Given this list of marker genes Yipf6, Trmt61b, Gm7369, Opn1sw, Prss41, Nherf2 (NCBI Gene Id 76520), Aim2, Gm25894, Gatad1, Amt, 9130213A22Rik, Slc35a4, Gphn, Yif1a, 2300009A05Rik, 1110018N20Rik, Akap7, Dok1, B230369F24Rik, Gm13624, Gm9873, Ldha, Fthl17f, Rps29-ps, Mir1894, Ech1, Gpr143 (G protein-coupled receptor 143), 2010109A12Rik, Hoxd3, Tanc1, Cyb5r4 (NCBI Gene Id 97535), Smarce1, Sec61a1, Ralgds, Phf21b, Sun2 (Sad1 and UNC84 domain containing 2), Sertad1, Mcm3ap, Tpd52l2 (NCBI Gene Id 99179), Nup155, Ccdc88c, Npas1, Dnah1, Zfp799, Tbl3, Slc3a2, Gm8098, Folr1, Tubgcp6, Mapk8ip2, Catsperg1, Gm12803, Calb1, Herpud1, Snap47, Sptbn1, R3hcc1l, Bbln, Nampt, D030040B21Rik, Ranbp17, Ctbp1, Tmtc1, Rnf167, Mtmr4, Nrtn, Izumo4, Ccdc191, Ubxn2b, Mid2, Exosc7, Patl1, Tedc1, Hpse, Trp53i11, Rbpms, Cpeb3, Ncor2, Mmaa, Gtf3c6, 4930568A12Rik, Atp6v0a2, Crabp2, Gm12222, Svil, Cdk19os, Ppp1r10, Actl6b, Trank1 (NCBI Gene Id 77478), Klhl15, Id2, Rfc5, Tbr1, Nfs1, Amfr, Gm2788, Mnx1, Zmym4, Mmp9 (matrix metallopeptidase 9), Ncoa5, Gcnt4, Atp6v1a, Tmem63c, Ndrg2, Lrrc41, Pdgfra, Zdhhc6, Gm14634, Uqcrh, Vti1a, Tpr, Swsap1, Wdr37, Fermt2, Ak6 (adenylate kinase 6), Mtcp1, Pgap4, Prorp, Cnot8, Gm24452, Ino80d, Srl, Tap1, Syndig1l, Cacng2, Mindy1, Mpped1, Lrriq4, Vgf, Grm2, Rnft2, Cox4i1, Ctrb1, Def8, Vim, Srpk1, Slc35e1, Cdyl, Elfn1 (NCBI Gene Id 243312), Uba52, Mob3a, Bcl2l11, Romo1, Ddr1, 2210016L21Rik, Calcoco2, Ccdc92b, Ugp2, Slc7a15, Adgrl1, Zfp687, E2f8, Eloc, Mcph1, Sympk (NCBI Gene Id 68996), Mier3, Ttl, Habp2, Kcnd3, Fyttd1, Gpr158, Aatf, Kcnk12, Emc8, Hrh3, Cln6, Sel1l3, Gm16794, Jmjd4, Qtrt2, Brcc3, Trp73, Ror1, Gm25855, Cyb561d1, Dennd4a (DENN domain containing 4A), Znhit1, Ino80c, Orc2, Cgrrf1, Exog, Hoxb9, Gm10699, Gmeb2, Cyp1b1, Yjefn3, Trpm8 (transient receptor potential cation channel, subfamily M, member 8), 2310065F04Rik, Glra1, Pknox1, Cox5a, Cited4, Echdc2, Tmem214, Frmd6, Lhx3, Slc25a11, Slc44a4, Cacng3, Ypel1, Tph2, Flt3, Ptpn5, Mrpl41 (NCBI Gene Id 20007), Ryr1, Riox2, Farp1, Alg8, Gm16576, St7, Lonrf2, Rnf207, Slc39a8, Nme2, Matr3, Otub2, Pxn, 5330439K02Rik, Nipbl, Psen1, Eef1a1, Pacsin3, Smim8, Zfp11, Notch1, Kcnb1, Kmt5b, Prtn3, Caskin2, Hmgn2, Gm16759 (NCBI Gene Id 102639582), Chrnb2, Gm17435, Arl6ip4, Ing1, Foxo6, Taf9, Zbtb41, Alg6 (ALG6 alpha-1,3-glucosyltransferase, NCBI Gene Id 320438), Pnpla7, Med14, Gm15295, Pold1, Tsr3, Barhl1, Ino80dos, Prep, Cyp20a1, 2610005L07Rik, Abca13, Mbnl2, Grin1, Mtg1, Erich1, Boll, Morn5, Zfp41, Rbm3, Dusp3, Pgk1, Xrn1, Atf7ip, Psmb9, Cdc16, Slc39a3, Plcl2, Etl4, 4930481B07Rik, Arhgef37, Kcnd3os, Mrps18b, Clstn3, Nrxn1, Ucp2, Gm23680, Pmaip1, Pfn2, Chmp6, Stx1a, Gprin1, Igf2bp1, Odr4, Gm2a, Klhl34, Mir431, Chordc1, Lrrk2, Rpp25l, Ank2, Cchcr1, Mypop, Foxa3, Tex2, Gldc, Unc45a, Hap1, Fastk, Mbtps2, Zfp729a, Nxph1, Nnmt, Htr5a, Slco4a1, Prpf38b, Stox2, Osbpl9, Tmem208, Mmp15 (matrix metallopeptidase 15), Lrp5, Tmem250, Disp2, Sinhcaf, Fyb1, H4c11, Spsb1, Phykpl, Fhit, Plppr3, Gm12692, Aasdh, Zdhhc3, Fbxl9 (F-box and leucine-rich repeat protein 9), Trmt10a, Rad17, Acbd5, Mttp, Kmt5c, Kdm4b, Hif3a, Amotl1, Adam22, Zfp423, Wdr35, Caprin2, Gm22379, Hk1os, Omg, Nkd2, Snord3a, Mir7b, Gm10101, Lrrcc1, Spmap2l, Eogt, Cartpt, Gm5805, Cox20, Smurf2, Tcf19, Trp53i13, Mrpl14 (NCBI Gene Id 68463), Ggh, Bambi, Fbll1, Megf6, Tap2, Uevld, Nr1h3, Pde4d, Loxl3, Pabpc5, Phf11d, Tlr3, Pax2, Letmd1, Ndufa13, Hsd17b12, Gm23123, Atxn7l2, Dennd3, Gm4890, Mcf2l, Neurod4, Slc20a2, Gm13392, Traf3, Nrg2 (NCBI Gene Id 381149), Macroh2a2, Aff1, Rbm45, Calr4, Mansc1, Cldn7, Gm26495, Asic3, Lmx1b, Spats2, Xrcc1, Vps13d, Trmt9b, Dbp, Bcan, Gm4835, Vdac3, Ankhd1, Ccdc90b, 2900041M22Rik, Mir675, Pm20d2, Cgn, Hint3, H19, Rubcn, Or2y10, Spop, Gtf3c2, Nos2, Rgs20, Gm25184, Deptor, Mapk11, Sh3kbp1, Dtx2, Rgs7, Rfc1, Slc5a11, Fbxl3, Caprin1, Gm15173, Nipsnap2, Acacb, Plekha1, Slc25a15 (solute carrier family 25 (mitochondrial carrier ornithine transporter), member 15), Scrt1, Tctn3, Gm21182, Cdk1, Ephb6, Dpf1, Mir138-2 (NCBI Gene Id 723956), Mtch2 (mitochondrial carrier 2), Tsen54, Gfod2, here is a description of the gene set: Mouse Gene Set: ZFP961_TARGET_GENES from publication Yevshin I, Sharipov R, Kolmykov S, Kondrakhin Y, Kolpakov F (PMID 30445619) species: Mus musculus